Given this list of marker genes PRDX6 (peroxiredoxin 6), CDK2AP1, ENO3, AURKAIP1, ACYP1, PRDX2, KDELR1, GM2A, NEK9, RAB1B, XPC (XPC complex subunit, DNA damage recognition and repair factor), QNG1, PAGR1, NDUFA4, IMPDH2, HDAC3, FAM3C, EDC4, COMTD1, HSPBP1, PNKP, P2RY1, UXT, EIF3A, SLC52A2, EMC10, MEF2D, VPS45, TRAM1, CHCHD7, ACO2, C1orf54, C1D, AFG3L2, CD300LD, PAF1, LMNA, ALDOA, FAM234B, MAPK14, SS18L2, GPAM, CDCA5, PTPN18, NNT, TMEM141, ZMAT3, HSD11B2, RGS18, TMEM131L, PBDC1, ATP1A3, PNPO, LSS, MYADM, PSMG1, ZFP64, PPP2R5D, UTP20, NCLN, ARPC4, IMP4, SLC7A5, NSMCE4A, PPP2R5C, CDC6, RECQL, DNAJB2, PRPF8, ADH5, NPTX1, NOP56, ATP5MC1 (ATP synthase membrane subunit c locus 1), ARHGAP1, NUP210, OGFOD3, EEIG1, HINT1, RNF187, CERK, HERPUD1, THRAP3, ADAM19, VPS29, NCF2, SNAP47, CHCHD10, FUCA2, LFNG, CCT5, ABHD8, DTYMK, C9orf78, NANS (N-acetylneuraminate synthase), ATP5ME, NAPSA, BRMS1, PLAC8, RPL13, SNX3, GALM, GNL3, SLC4A1AP, TLE5, EIF3I, TMEM126A, NREP, SLC29A3, RPL22, MAP4K1 (NCBI Gene Id 11184), MRPL45, SND1, TIMM50, TRIB1, ABHD14A, COQ5, AARSD1, NOL12, NFIL3, COX8A, EMILIN1, KCTD12, MYDGF, TIAM2, HMG20B, CDK5RAP3, EBPL, POLE3, TFEB, ETFBKMT, SMARCA2, COLGALT1, PTGER2, OMA1, PON2, TEF, TTC8 (tetratricopeptide repeat domain 8), CSNK1G2, GPR89B, PRXL2A, KPNA2, NAA38, ACOT7, TMEM234, ZNF362, KRT5, TBC1D22A, ELP3, LRWD1 (NCBI Gene Id 222229), DENND10, ARAF, EEF1AKMT1, MYH7, DAP3, NEO1, NR2C2AP, MTX2, AFG1L, CLNS1A, PROS1, STK11IP, F5, SMAP2, ANP32B, ARG1, FANCL, DGCR6 (DiGeorge syndrome critical region gene 6), BTK, HSPA8, RPL27A, CTDSP1, PMM1, WDR45, MCM10, ALYREF, E2F6, BLTP2, HSF2, PYCR2, P2RY6, EWSR1, ALDH18A1, MCUB, TNS1, NAGA, LTBR (NCBI Gene Id 95898), DCTN4, NUCB2, APOC2, MIA2, MLF2, KIAA0930, DPH5, EPRS1, LPGAT1, GBF1, DDB1, SYS1, OSBPL2, here is a description of the gene set: Genes up-regulated in comparison of dendritic cells (DC) stimulated with Gardiquimod (TLR7 agonist) at 0.5 h versus those stimulated with Gardiquimod (TLR7 agonist) at 8 h. Human Gene Set: GSE17721_0.5H_VS_8H_GARDIQUIMOD_BMDC_UP mouse primary BMDCs were stimulated with tlr ligands and gene expression changes were profiled on Affymetrix arrays species: Homo sapiens from publication Amit I, Garber M, Chevrier N, Leite AP, Donner Y, Eisenhaure T, Guttman M, Grenier JK, Li W, Zuk O, Schubert LA, Birditt B, Shay T, Goren A, Zhang X, Smith Z, Deering R, McDonald RC, Cabili M, Bernstein BE, Rinn JL, Meissner A, Root DE, Hacohen N, Regev A (PMID 19729616)